The following is a description of a gene set: Mouse Gene Set: GOBP_MICROTUBULE_BASED_TRANSPORT studied in species Mus musculus A microtubule-based process that results in the transport of organelles, other microtubules, or other cellular components. Examples include motor-driven movement along microtubules and movement driven by polymerization or depolymerization of microtubules., and this is the list of marker genes: Cdc42, Fez1, Hif1a, Ift70a1, Dync2i1, Odad3, Ubb, Bicd1, Ank3, Dnaaf4, Spg7, Arl8b, Rsph4a, Lca5l, Mak, Terf2, Gas8, Cilk1, Trim46, Spag6l, Tub, Agbl4, Nme5, Spef2, Spag16, Dync1i2, Ift70b, Kif5c, Kif3b, Trim58, Kifc2, Kif21b, Cln3, Ift74, Ofd1, Mecp2, Kif16b, Dnai1, Vangl1, Nefl, Bicd2, Syne2, Ap3m1, Spg11, Ap3s2, Rasgrp1, Bbs1, Spast, Kifap3, App, Ift88, Dnah11, Mapk8ip3, Htt, Rsph9, Actr10, Megf8, Wdpcp, Bsn, Flot2, Spag17, Sun1 (NCBI Gene Id 77053), Ift80, Map1b, Mreg, Myo5a, Kif2a, Copg2, Cfap43, Klc3, Clip3, Ift22 (NCBI Gene Id 67286), Armcx3, Stau1, Ift57, Ift27, Mgarp, Dynlt2b, Map6, Borcs5, Borcs8, Wdr35 (NCBI Gene Id 74682), Snapin, Cfap45, Drc1, Hnrnpu, Rfx3, Rsph14, Klc2, Ccdc39, Cluap1, Rpgr, Pex14, Ssx2ip, Arl8a, Aqp4, Stau2, Dync2i2, Fbxw11, Dync2h1, Rab27b, Ttll1, Spag6, Jhy, Ift52, Pafah1b1, Daw1, Dst, Dnah5, Kif1a, Bloc1s2, Kif5b, Gmnc, Map1a, Tmem201, Ropn1l, Ap3b1, Kifbp, Cnih2, Rabgef1, Bloc1s6, Ccdc40, Kif13a, Camsap3 (calmodulin regulated spectrin-associated protein family, member 3), Kif17, Map2, Nherf1, Kif5a, Ap3s1, Dync1i1, Map2k1, Arhgap21, Stard7, Ift122 (NCBI Gene Id 97320), Ift25, Cep131, Wasf1 (WASP family, member 1), Ttc21b, Kifc1, Cfap54, Prkcz, Neto1, Hdac6, Hsbp1, Nde1, Sfpq, Kif1c, Atg5 (autophagy related 5), Nme7, Stk36, Intu, Bloc1s1, Bloc1s5, Ccdc103, Odad4, Dync2li1, Dnaaf3, Caly, Kif27, Rab17, Ttc21a, Kif28, Rsph1, Arl3, Uchl1, Tuba1a, Ulk4, Copg1, Tmem230, Hspa8, Ssna1, Trak1, Rab1a, Hspb1, Bloc1s4, BC048507, Katnip, Lca5, Ift172, Sod1, Pura, Mapt, Sybu, Invs (inversin), Lamp1 (lysosomal-associated membrane protein 1), Klc1, Ak7, Kif21a (NCBI Gene Id 16564), Dlg2, Ap3b2, Rsph3b, Ift46, Ift70a2, Nefh, Dydc1, Kif3a (NCBI Gene Id 192824), Atg16l1, Ift56, Iqub, Ift43, Kxd1, Dnaaf2, Dnajb13, Ift81, Rab21, Borcs6, Dnah1, Cwh43, Stk11, Dpcd, Bicdl2, Dnah9, Cfap221, Nefm, Wdr19, Dtnbp1, Ccdc88c, Bicdl1, Dync1h1, Adcy10, Rhot2, Madd, Dynll1, Gja1, Sun2, Borcs7, Bbs12, Ccdc38, Tmem108, Rhot1, Traf3ip1, Ift20, Ap3m2, Kif1b, Cfap53, Fuz, Trak2, Pcm1, Ift140, Ap3d1, Bloc1s3, Dnaaf11, Ndel1, Fyco1, Agtpbp1, Hap1, Nek10